Given this list of marker genes PDK3, MT-TE, NR4A2, ATN1, PRORP, PRX, CADM3, DNAJC3 (NCBI Gene Id 5611), SETX, XK, ATL1, PLS1, MPZ, PNPT1, PDXK (pyridoxal kinase), UBAP1, HAX1, PLD3, GNB4, LRSAM1, GPI, MT-ATP6, SCO2, RFC1, ERLIN2, AARS1, NDRG1, UCHL1, PIEZO2, STUB1, GCH1, HARS1, OPA3, SPAST, ABCB7, FXN, TWNK, GBA2, TTR, BSCL2, KIF5A, SPTLC2, JAG1, NIPA1, ABCD1, ARSI, SPG7, IRF2BPL, SPART, ZFYVE26, KCND3, HINT1, MPV17 (mitochondrial inner membrane protein MPV17), SPG11, ALDH18A1 (aldehyde dehydrogenase 18 family member A1), SH3TC2 (SH3 domain and tetratricopeptide repeats 2), CAMTA1, LMNB1, DHTKD1, EGR2, NEFH (NCBI Gene Id 4744), FLVCR1, KIF1A, SPTAN1, NAGLU, MORC2 (NCBI Gene Id 22880), PIK3CD, KPNA3, XRCC1, ATXN8OS, REEP1, PMP22, HSPD1, RNF170, BEAN1, PLOD1 (procollagen-lysine,2-oxoglutarate 5-dioxygenase 1), VPS41, GDAP1, ITPR1, POLR3B, MTTP, HK1, TDP1, SPTLC1, PRKCG, SCN9A, WDR48, DARS2, AMPD2, DCAF8, VPS13A, FMR1, DDHD1, ATXN2, REEP2, CPT1C, SCP2 (NCBI Gene Id 6342), CLDN9, SACS, ATP1A1, RNASEH1, IMPDH2, DHH (NCBI Gene Id 791256), KCNC3, SLC12A6, NGF, ATP13A2, FLRT1, APTX, CHP1, PMP2, POLG, KNSTRN, GARS1, MFN2, SAR1B, TGM6, RTN2, ERBB3, PNKP, SPTBN2, MTRFR, POLR3A, PEX6, ENSG00000288330, CYP7B1, CACNA1G, PEX10, KLHL9, SAMD9L, LITAF, SYNE1, PLEKHG4, SORD, NEFL, VCP, PDYN, TBP, CHCHD10, TTPA (NCBI Gene Id 7274), TPP1, B4GALNT1, VAMP1, SLC33A1, KLC2, PRDM12, POU4F1, ATXN1, VPS13D, SLC25A15, FGF14, VPS37A, ATXN3, PI4KA, MAG, WASHC5, RIPOR2, here is a description of the gene set: Human Gene Set: HP_IMPAIRED_PROPRIOCEPTION Impaired proprioception A loss or impairment of the sensation of the relative position of parts of the body and joint position. species: Homo sapiens